The following is a description of a gene set: from publication Cui A, Huang T, Li S, Ma A, Pérez JL, Sander C, Keskin DB, Wu CJ, Fraenkel E, Hacohen N (PMID 38057668) species: Mus musculus Mouse Gene Set: CUI_TREG_GM_CSF_RESPONSE_UP Cytokines mediate cell-cell communication in the immune system and represent important therapeutic targets. A myriad of studies have highlighted their central role in immune function, yet we lack a global view of the cellular responses of each immune cell type to each cytokine. To address this gap, the authors created the Immune Dictionary, a compendium of single-cell transcriptomic profiles of more than 17 immune cell types in response to each of 86 cytokines (>1,400 cytokine-cell type combinations) in mouse lymph nodes in vivo. A cytokine-centric view of the dictionary revealed that most cytokines induce highly cell-type-specific responses. For example, the inflammatory cytokine interleukin-1β induces distinct gene programmes in almost every cell type. A cell-type-centric view of the dictionary identified more than 66 cytokine-driven cellular polarization states across immune cell types, including previously uncharacterized states such as an interleukin-18-induced polyfunctional natural killer cell state. Genes positively differentially expressed in cell type: Treg upon treatment with cytokine: GM-CSF in mouse lymph nodes in vivo., and this is the list of marker genes: Snhg6, Anxa5, Mboat7, Usp3, Tmsb10